The following is a description of a gene set: The series of molecular signals initiated by apolipoprotein A-I binding to its receptor on the surface of a target cell, and ending with the regulation of a downstream cellular process, e.g. transcription. studied in species Homo sapiens Human Gene Set: GOBP_APOLIPOPROTEIN_A_I_MEDIATED_SIGNALING_PATHWAY, and this is the list of marker genes: RHOA, MIR33A, ITGB3, ABCA7, ITGAV, MIR19B1, ABCA1 (NCBI Gene Id 8371)